The following is a description of a gene set: part of: Acetylcholine binding and downstream events studied in species Mus musculus Reactome Pathway: Postsynaptic nicotinic acetylcholine receptors This event has been computationally inferred from an event that has been demonstrated in another species.<p>The inference is based on the homology mapping from PANTHER. Briefly, reactions for which all involved PhysicalEntities (in input, output and catalyst) have a mapped orthologue/paralogue (for complexes at least 75% of components must have a mapping) are inferred to the other species. electronically inferred by orthology from the curated human pathway, and this is the list of marker genes: Chrne, Chrna4, Chrnb2, Chrna7